The following is a description of a gene set: Human Gene Set: FXR_Q3 species: Homo sapiens Genes having at least one occurrence of the motif CARGKTSAWTRACC in the regions spanning 4 kb centered on their transcription starting sites. This matches the NR1H4 transcription factor binding site V$FXR_Q3 (v7.4 TRANSFAC)., and this is the list of marker genes: NFATC1, ATAD5, AAMP, NR2F1, NR2E1, PDE1A, POLR3GL, VAMP2, ABCG4, CPSF7, KLF9, GRIK3, BAMBI, RNF133, TRIB1, AKNA, FABP6, OR4D5 (NCBI Gene Id 79474), WDR81, R3HDM1, PIK3CG, ITPR1, TRMT10A, ZIC1, MLLT6, GNB2, FBRS, NPTX2, IL2RG, MACF1, WNK4, NR0B2, OTX2, SATB1, UBL3, EGR2, KIN, HOXC6, C1QTNF7, IL21, ATP5F1C, VASN, MIR22HG, FBXO9, IL20RB, HSPB2, ATXN1, PENK, OTP, SV2A, CCDC24, G6PC1, SWAP70, FHL3, PNKD, LMO3, MOS, ZIC4, ORMDL3, FUT8, MET, NTRK3, KLF14, WDR20, AMMECR1L, SPOCK2, PRSS36, STC2, HAS2, C8A, KIF5A, DMD, ATOH7, SP6, SDHAF2, GSX1, MAP3K20, RUNDC3A, OCLN (occludin), ITIH3, VEGFA, GUCY2F, EYA1, THNSL2, APP, BRCA1, LINC00671, BMP5, MEIS2, KIF3B, PCDH7, KCTD15, FGF14, TMEM263, SYT17, VCPKMT, MICAL2, SLITRK2 (SLIT and NTRK like family member 2), EFEMP2, C6orf62, NRIP3, NUDCD1, PRSS50, FEZF2, IBSP, NBR2, ADO, SLC4A11, ZBED5, TNFSF15, STOML2, PTCHD4, FES (FES proto-oncogene, tyrosine kinase), LHX1 (LIM homeobox 1)